Given this list of marker genes PIK3C2A, EFL1, UFSP2, LONP1, LRRK1, IDH1, SBDS, TGFB1 (transforming growth factor beta 1), ALG3, DNAJC21 (NCBI Gene Id 134218), PTH1R, NKX3-2, GPX4, RUNX2, GJA1, CWC27, RMRP, POP1, EIF2AK3, CDKN1C, TMEM53, COL2A1, TMEM165, MMP13, HDAC6, DYM, LBR, EXTL3 (exostosin like glycosyltransferase 3), SFRP4, COL10A1, ACP5, AIFM1, POLE, FGFR3, SRP54, here is a description of the gene set: studied in species Homo sapiens Metaphyseal dysplasia The presence of dysplastic regions in metaphyseal regions. Human Gene Set: HP_METAPHYSEAL_DYSPLASIA